The following is a description of a gene set: Human Gene Set: GOBP_LEYDIG_CELL_DIFFERENTIATION studied in species Homo sapiens The process in which a relatively unspecialized cell acquires specialized structural and/or functional features of a Leydig cell. A Leydig cell is a testosterone-secreting cell in the interstitial area, between the seminiferous tubules, in the testis., and this is the list of marker genes: PDGFRA, AMH, SGPL1, DHH (NCBI Gene Id 791256), NKX2-1, NR5A1, TMF1, PLEKHA1, CCND1, NR0B1, AR